The following is a description of a gene set: A process that is carried out at the cellular level which results in the arrangement of constituent parts of a phagosome within a cell. Phagosome maturation begins with endocytosis and formation of the early phagosome and ends with the formation of the hybrid organelle, the phagolysosome. Mouse Gene Set: GOBP_PHAGOSOME_MATURATION studied in species Mus musculus, and this is the list of marker genes: Syt11, Mtmr4, Rab38, Cln3, Rab32, Syt7, Spg11, Unc13b, Rab34, Pikfyve, P2rx7, Rab7, Rab7b, Slc9a9, Rab20, Rab31, Tmem175, Myo7a, Slc4a7 (solute carrier family 4, sodium bicarbonate cotransporter, member 7), Coro1a, Pla2g5, Arl8b, Tcirg1, Mcoln1, Mreg, Rab14, Rab43, Rab39, Slamf8, Srpx